Given this list of marker genes UCKL1, UCK1, UPP2, UPP1, DCK, TK2, PUDP, TK1, CDA, UCK2, TYMP, here is a description of the gene set: Pyrimidine salvage studied in species Homo sapiens Human Gene Set: REACTOME_PYRIMIDINE_SALVAGE